Given this list of marker genes ABCB6, HPX, PGRMC2, FLVCR1, SLC46A1, ABCC5, FLVCR2, SLC48A1, ABCB7, here is a description of the gene set: studied in species Homo sapiens Enables the transfer of heme from one side of a membrane to the other. Human Gene Set: GOMF_HEME_TRANSMEMBRANE_TRANSPORTER_ACTIVITY